Given this list of marker genes CCND1, IER3, TNFAIP2, CDK4, THBD, ANXA3, GAS6, G0S2, SAE1, EIF3C, SOX4, FGF7, PDCD2, TUBB, CD81, DDB1, CD44, CXCL12, UBTF, GAS7, CCT5 (chaperonin containing TCP1 subunit 5), THBS1, CEBPD, BAX, AKR1B1, CCL2, IL4R, SDC1, CRYAB, ANXA5, ATF1, XDH, ZNF148, ANXA2, CD9, BID, VDR, IFRD1, PDGFRB (NCBI Gene Id 5159), PLAT, DNAJB1 (NCBI Gene Id 3337), TUBA1A, GAS1, CCL7, CDC37, UCP2, CCT2, EEF2, HGFAC, CCND2, ECM1, IL11RA, SAMHD1, HSPA8, CCN1, ITGB1, THBS2, IL1R1, CCN2, FN1, VCAN, CASP8, MMP14, here is a description of the gene set: from publication Gerhold DL, Liu F, Jiang G, Li Z, Xu J, Lu M, Sachs JR, Bagchi A, Fridman A, Holder DJ, Doebber TW, Berger J, Elbrecht A, Moller DE, Zhang BB (PMID 12021175) Selected genes down-regulated during differentiation of 3T3-L1 cells (fibroblast) into adipocytes in response to adipogenic hormones. PPAR gamma is an adipocyte-specific nuclear hormone receptor. Agonists of PPAR gamma, such as thiazolidinediones (TZDs), promote adipocyte differentiation and have insulin-sensitizing effects in animals and diabetic patients. Affymetrix oligonucleotide arrays representing genes were employed to profile the gene expression responses of mature 3T3-L1 adipocytes and differentiating preadipocytes to a TZD PPAR gamma agonist in vitro. The expression of genes was significantly up- or down-regulated by more than 1.5-fold during differentiation and/or by treatment with TZD, and these genes were organized into 32 clusters that demonstrated concerted changes in expression of genes controlling cell growth or lipid metabolism. Quantitative PCR was employed to further characterize gene expression and led to the identification of beta-catenin as a new PPAR gamma target gene. Both mRNA and protein levels for beta-catenin were down-regulated in 3T3-L1 adipocytes compared with fibroblasts and were further decreased by treatment of adipocytes with PPAR gamma agonists. Treatment of db/db mice with a PPAR gamma agonist also resulted in reduction of beta-catenin mRNA levels in adipose tissue. These results suggest that beta-catenin plays an important role in the regulation of adipogenesis. Thus, the transcriptional patterns revealed in this study further the understanding of adipogenesis process and the function of PPAR gamma activation. species: Mus musculus Human Gene Set: GERHOLD_ADIPOGENESIS_DN